Given this list of marker genes Scaf4, Scaf1, Leo1, Hnrnpu, Pcif1, Rprd1b, Scaf8, Rprd2, Brd4, Rprd1a (regulation of nuclear pre-mRNA domain containing 1A), Rtf1, here is a description of the gene set: Binding to the C-terminal domain (CTD) of the largest subunit of RNA polymerase II. The CTD is comprised of repeats of a heptapeptide with the consensus sequence YSPTSPS. The number of repeats varies with the species and a minimum number of repeats is required for RNAP II function. Mouse Gene Set: GOMF_RNA_POLYMERASE_II_C_TERMINAL_DOMAIN_BINDING studied in species Mus musculus